Given this list of marker genes HHEX, RAB2A, CLOCK, PLPP4, GDNF, ZNF652, TSPAN3, NOM1, DSEL, BAZ1A, TMEM263, BRWD3, MGST3, TRIM73, TMEM254, NPAS2, MAF, ZIC2, IFIH1, RTP2, CLEC9A, SEPTIN2, ZNF621, TPRG1L, MAP10 (NCBI Gene Id 54627), MAT2A, ZNF347, DCAF12L2, ERICH3, PEX5, BBX, PRICKLE1, NFIB, ZBTB18, MSL2, ALS2, TSPAN12, ADAR, GBP4, NR2C2, SEMA5B, MED13L, EPHA5, JADE1, SMAGP, EYA4, REEP3, ABHD5, FLT1, PRKDC, TRIM74, ZNF518B, ATAD2B, RAP2A, here is a description of the gene set: from publication Chen Y, Wang X (PMID 31504780) Human Gene Set: MIR3137 Genes predicted to be targets of miRBase v22 microRNA hsa-miR-3137 in miRDB v6.0 with MirTarget v4 prediction scores > 80 (high confidence targets). species: Homo sapiens